Given this list of marker genes Lrsam1, Arfip1, Mcpt1, Pxn, Hspa12a, Ctso, Tbkbp1, Cdadc1, Pskh1, Xpo7, Tnrc6b, Prkar1b, Ermp1, Abhd4, Ccna2, Stk25, Sh3pxd2a, Mal2, Susd2 (NCBI Gene Id 71733), Mpdu1, Agtr1b, Dusp9, Phactr1, Plxna1, Mat2a, Fli1, Hmox1, Adcy9, Dennd11, Cdr2l, Zfx, Rab6b, Tanc2, Pdxk, Gab2, Sfxn1, Acot11, Adora2a, Mad1l1 (NCBI Gene Id 17120), Tmed5, Rabgap1, Kif2c, Mllt11, Rbmx, Pggt1b, Vav3, Nfyc, Itga5, Zfp106, Mecp2, Fggy, Ptprf, Ehd2 (EH-domain containing 2), Crhr2, Mical2, Sidt2, Magi1, Skint3, Scimp, Tmem209, Elmod1, Pnrc1, Hexim2, Slc25a40, Cd320, Kdelr1, Vat1, Dpp10, Zbtb4, Srcap, Slc25a42, Cphx1, Sord, Csmd2, Fgf18, D6Ertd527e, Kcnk3, Krtap4-7, Tgfbrap1, Tent4b, Nkd1, Zranb2, Wdr48, Fbrs, Tet3, Ppp1r1b, Lipt2, Pou3f3, Gpr37l1, Selenon, Nr6a1, Clcf1, Tex261, Nr1i3, Heyl (hairy/enhancer-of-split related with YRPW motif-like), Eeig1, Fbxl20, Eipr1, Adam19, Ptprcap, Cacng6, Syt3, Alkbh6, Fbxl17, Dhx33 (NCBI Gene Id 73199), Capn12, Lasp1, Iqsec3, Plagl1, Tspan2, Fancd2, Aqp9, Sars1, Cyp2s1, Kcnj10, Tbc1d15, Niban2, Eda, Adra1a, Lbh, Scd1, Pin1, Sox6, Lzts3, Prom2, Atxn1l, Mtrf1l, Rnf44, Shisal1, Psmd8, Numa1, Atp8b2, Ccdc178, Krtap5-2, Meis2, Nsd1, Naa40, Kcnma1, B3galt1, Ubiad1, Lypd6 (LY6/PLAUR domain containing 6), Dcun1d3, Cdk5r2, Igsf9b, Cic, Caskin1, Dagla, Spart, here is a description of the gene set: from publication Chen Y, Wang X (PMID 31504780) Mouse Gene Set: MIR_8108 species: Mus musculus Genes predicted to be targets of miRBase v22 microRNA mmu_miR_8108 in miRDB v6.0 with MirTarget v4 prediction scores > 80 (high confidence targets).